Given this list of marker genes Cyp26c1, Cyp26a1, Strap, Sp1, Cyp4f40, Cbr3, Cyp24a1, Klf9, Cyp27b1 (cytochrome P450, family 27, subfamily b, polypeptide 1), Cyp26b1, Cyp2w1 (NCBI Gene Id 640150), Fgf23, here is a description of the gene set: Mouse Gene Set: GOBP_FAT_SOLUBLE_VITAMIN_CATABOLIC_PROCESS studied in species Mus musculus The chemical reactions and pathways resulting in the breakdown of any of a diverse group of vitamins that are soluble in organic solvents and relatively insoluble in water.